Given this list of marker genes PSMD14, DAB2, CYFIP1, MRPS35, MGST3, SYPL1, TPP1, NDUFS1, PEBP1, CACYBP, IMP4, SDAD1, SRSF7, IARS2, TIMM10B, TMEM14B (transmembrane protein 14B), LRRC8D, MAOA, ZNF207, SOAT1, CHCHD3, XRCC6, AKIP1, AIFM1, KIAA0930, ARMC1, UQCRH, EVL, UROD, RAD50, STIP1, PFDN1, RREB1, CTNNA1, CSNK2A1, UTP3, HSPE1, GLS, UBE2V2, PSMD5, M6PR, RBX1, TIGAR, HLA-DMA, VDAC2, EOLA1, ATP5MC3, CAPN2, RBBP7, TRPV2, MPV17, PAIP1, ATRAID, TRAM1, SNRPD3, PSMG2, COMMD3, MTHFD2, TSPAN3, FBXL14, CBFB, SUMO3, CITED2, UBE3C, NMT1, SUCLG2, CAPRIN1, CD81, TRA2B, MITF, RAN, ANXA5, ATP13A1, AIMP1, SLC9A6, CANX, SEM1, RPA1, RIOX1, ZNF804A (NCBI Gene Id 91752), TMX2, RALA, NUP37, BUD23, PRDX1, SUCLG1, PSMD1 (proteasome 26S subunit, non-ATPase 1), MRPL34, TIAM1, ATP1B1 (NCBI Gene Id 481), NDUFB8, ATP5F1B, SRSF3, ESD, GLO1, TBL1XR1, CEBPA, NDUFV2, CNOT1, TMEM243 (transmembrane protein 243), MTCH2, HCCS, CCT8, FBXO7, DERL1, SEC31A, YBX1, GSTP1 (glutathione S-transferase pi 1), NDUFB4, PRDX3, INTS14, CYC1, CUL5, RTRAF, UTP18, CDC42BPB, SMARCE1, CLSTN1, VDAC3, DUSP3, RNH1, MRPS7, KTN1, DNM1L, CLNS1A, SLC7A8, LRPPRC, HLA-DRA, BANF1, GTF2A2, METAP2, MRPL15, PCCB, OPN3, GTF2H5, ATXN10, ABCB7, GRAMD4, PDHX, MTREX, MAP2K1, ADO, FAF1, TUFM, GPX1, PEA15, APPL1, MAN2B1, PSMC2, CCDC47 (coiled-coil domain containing 47), ANKRD17, EIF4G1, GPX3, ZFYVE21, MRPS15, SFPQ, PSMA3, SSR4, GNL2, ATP5F1A, NCOR2, PTPN18, EHD4, XBP1, TMEM147, GPR137B, CCT4, NDUFAB1, VTI1B, MDFIC, DOCK10, POP4, NIPSNAP2, SNX2, MRPL40, MRPL35, VCP, ATP5PD, ECHS1, ATP6V1F, CUL1, TMEM165, HMGN3, EIF2B2, FBXO21, GOT2, SEPTIN2, RNF14, ANKRD10, NOL7, YIF1A, UFC1, TGIF1, FCER2, TXN, HSPA9, PFKP, SGSH, GCLC, GSN, here is a description of the gene set: studied in species Homo sapiens from publication Abbas AR, Baldwin D, Ma Y, Ouyang W, Gurney A, Martin F, Fong S, van Lookeren Campagne M, Godowski P, Williams PM, Chan AC, Clark HF (PMID 15789058) Human Gene Set: GSE22886_NEUTROPHIL_VS_DC_DN Genes down-regulated in comparison of neutrophils versus dendritic cells (DC). Immune cell-specific expression is one indication of the importance of a gene's role in the immune response. In order to identify such patterns, we set out to broadly profile gene expression in a variety of immune cells.